Given this list of marker genes MT1X, EGR1, FAS, PSMD3, HSPA1B (NCBI Gene Id 3304), FDXR, CYP1B1, DKK1, JUN, UTP25, H19, GDF15, PPP2CB, EDN1, RPL38, MT1H, LIF, NQO1, EPS8L2, PSMD12, HMOX1, RCBTB1, DDIT3, ZBTB4, LRP6, MIA2, PLA2R1, SLC35B3, here is a description of the gene set: Human Gene Set: CHUANG_OXIDATIVE_STRESS_RESPONSE_UP species: Homo sapiens Global gene expression patterns in breast cancer cells after treatment with oxidants (hydrogen peroxide, menadione, and t-butyl hydroperoxide) were investigated in three replicate experiments. RNA collected after treatment (at 1, 3, 7, and 24 h) rather than after a single time point, enabled an analysis of gene expression patterns. Using a 17,000 microarray, template-based clustering and multidimensional scaling analysis of the gene expression over the entire time course identified genes as being either up- or down-regulated by the three oxidants. In contrast, only genes were identified for any single time point and a 2-fold change criteria. Surprisingly, the patterns of gene induction were highly similar among the three oxidants; however, differences were observed, particularly with respect to p53, IL-6, and heat-shock related genes. Replicate experiments increased the statistical confidence of the study, whereas changes in gene expression patterns over a time course demonstrated significant additional information versus a single time point. Analyzing the three oxidants simultaneously by template cluster analysis identified genes that heretofore have not been associated with oxidative stress. from publication Chuang YY, Chen Y, Gadisetti, Chandramouli VR, Cook JA, Coffin D, Tsai MH, DeGraff W, Yan H, Zhao S, Russo A, Liu ET, Mitchell JB (PMID 12414654) Genes up-regulated in MCF7 cells (breast cancer) after treatment with the oxydants: hydrogen peroxyde, menadione, and t-butyl hydroperoxyde.